Given this list of marker genes MLANA, GBP3, IRX3, STK32A, DAW1, CREBL2, FEM1C, AGFG1, DNAJB4, NCBP3, INTS6, EID1, SLC39A9, GUCY1A2, PURG, HAL, CSF1, ANKRD42, STRA6, YY2, ZDHHC21, SERAC1, CIMIP1, HNRNPH3, USP9X, DNM3, PTEN, LRRC8E, MTPN, ABHD17B, ASB5, EPM2AIP1 (EPM2A interacting protein 1), GLT6D1, GMCL1, ANKRD50, IQGAP3, IRGQ, ZNF124, BCL2L15, SRSF1, RAB27B, PPP1R9A, STAMBP, PCDHB9, DUSP6, SF3B5, RAB4B, DROSHA, EEF1E1, CCDC141, COL6A5, TMEFF2, POLQ, SRP14, NBR1, ENSG00000255537, NFE2L2, ACBD6, CPS1, ADGRV1, RHOT1, EFCAB2, IGF2, GABRB2, PANX1, EPN2, PTAR1, TRPM1, EPHA3, SPATA46, ZNF850, WNT9B, TMSB4Y, NIP7, TCTN3, MDM4, FER, SMURF2, ZDHHC17, SPRED1, MSN, ING3 (inhibitor of growth family member 3, NCBI Gene Id 54556), CAMTA1, ZYG11B, AASDH, CCNA2, SOBP, ZNF827, TBC1D7, PTP4A1, here is a description of the gene set: from publication Chen Y, Wang X (PMID 31504780) Genes predicted to be targets of miRBase v22 microRNA hsa-miR-4662a-5p in miRDB v6.0 with MirTarget v4 prediction scores > 80 (high confidence targets). Human Gene Set: MIR4662A_5P studied in species Homo sapiens